The following is a description of a gene set: Mismatch Repair studied in species Homo sapiens Human Gene Set: REACTOME_MISMATCH_REPAIR, and this is the list of marker genes: RPA3, LIG1, EXO1, RPA2, PMS2, RPA1, MSH3, POLD4, MSH6, MSH2, MLH1, PCNA, POLD1, POLD3, POLD2